The following is a description of a gene set: Human Gene Set: GOBP_SCHWANN_CELL_PROLIFERATION species: Homo sapiens The multiplication or reproduction of Schwann cells, resulting in the expansion of their population. Schwann cells are a type of glial cell in the peripheral nervous system., and this is the list of marker genes: RNF10, ASCL2, CERS2, DICER1, NF1, MIR222, NF2, SKI, GFAP, SOX10, MIR221 (microRNA 221)